The following is a description of a gene set: The directed movement of substances, into, out of or within a cell, either in a vascular tissue or in the vascular membrane. Human Gene Set: GOBP_VASCULAR_TRANSPORT studied in species Homo sapiens, and this is the list of marker genes: SLC29A1, LEPR, ABCC4, ABCC2, ABCA2, SLC4A4, SLC4A3, SLC2A1, SLC5A3, CD36, SLC7A2, SLC2A10, SLC22A2, MFSD2A, SLC5A5, SLC16A1 (solute carrier family 16 member 1), SLC38A5, SLC27A4, AVPR1B, SLC7A8, SLC7A3, SLC2A13, ABCB1, SLC8A2, SLC4A8, FABP5, ATP1B2, ABCC3, INSR, LRP2, SLC29A4, SLC6A17, SLC27A1, ATP1A2, FLVCR2, SLC44A1, SLCO2B1, SLC38A1 (NCBI Gene Id 81539), SLC1A3 (NCBI Gene Id 6507), SLC6A6, APOE, ABCC9, SLC13A3, SLC5A1, SLC1A5, ABCC5, ATP2A3, SLC22A3, SLC6A1, SLC7A5, SLC1A2, SLC19A1, SLC7A1, ABCC1, KCNJ8, SLC38A3, SLC22A1, SLC6A13, SLC22A8, AVPR1A, SLC28A2, ABCG2, SLCO1C1, SLC22A5, SLC6A9, SLC29A2, SLC2A3, SLC16A12, AGER, SLC16A7, NHERF1, SLC24A3, SLC1A1, TFRC, SLCO3A1, LRP3, SLC12A2, SLC6A20, SLC38A2, SLC15A2, ATP1A4, ATP8A1, SLC1A4, SLC5A6, LRP1 (NCBI Gene Id 4035), ATP2B4, SLC16A2, SLC2A4